Given this list of marker genes Sult2a5 (NCBI Gene Id 434264), Sult2a2, Sult2a1 (NCBI Gene Id 20864), Sult2a8, Sult2a4, Sult2a3, Sult2a6, Sult1c1, Sult2a7, here is a description of the gene set: Catalysis of the reaction: 3'-phosphoadenosine 5'-phosphosulfate + taurolithocholate = adenosine 3',5'-bisphosphate + taurolithocholate sulfate. species: Mus musculus Mouse Gene Set: GOMF_BILE_SALT_SULFOTRANSFERASE_ACTIVITY